Given this list of marker genes ZNF737, TOB1, C6orf89, IGF2R, FTMT, MTCL2, ZBTB39, PHF8, ZNF284, EP300, SSH3, DDHD1, ADI1, UNC80, HOXA1, SLC27A4, ZNF513, PATE3 (NCBI Gene Id 100169851), ATP6V0E1, TNS4, NCCRP1, FICD, PDLIM7 (NCBI Gene Id 9260), SH3RF2, CLN8, MDGA1, ZFX, PURB, KRT4, COL11A2, SAMD10, BACH2, PDGFB, RAB44, SLC16A14, ABHD13, ZNF286A, ADCY5, METTL21A, NECTIN1, BRSK2, PLEKHS1, MSI2, ZNF286B, PLXNC1, ADAM19, PMM2 (NCBI Gene Id 5373), SAP30BP, GRM5, HOMER1 (NCBI Gene Id 9456), RSPO4, ZNF609, ZNF253, SIRPB1, BCAM, DIAPH1, EIF4A1, SDK2, GDPD4, NCOR2, TLE5, CYB5R2, PDE4D, PLAGL2, CFAP44, EHD4, HEPACAM, VPS13C (NCBI Gene Id 57581), ATP1B4, CLYBL, PNKD, POU4F1, PDLIM3, ERG28, XPNPEP3, SHOX, GTPBP1, CAPN6, ST3GAL1, AMOT, ZSWIM6, MLXIPL, OS9, USP22, LRRC27, ALG9, SOX6, DOC2A, TFCP2L1, INSYN2B, PLXNA4, SLAMF6, RIMS4, NPPC, MAMLD1, LDLRAD2, FMNL3, HECTD3, KAT7, ZNF385A, WDR33, here is a description of the gene set: Human Gene Set: MIR3689D from publication Chen Y, Wang X (PMID 31504780) Genes predicted to be targets of miRBase v22 microRNA hsa-miR-3689d in miRDB v6.0 with MirTarget v4 prediction scores > 80 (high confidence targets). species: Homo sapiens